The following is a description of a gene set: studied in species Homo sapiens Megacystis Human Gene Set: HP_MEGACYSTIS Dilatation of the bladder postnatally., and this is the list of marker genes: NKX2-1, MYLK, LMOD1, ACTG2, AVPR2, TP63, MYH11, MYL9, AQP2, LRIG2